Given this list of marker genes RIPK1, PTPN2, IL6, MIR99A, MIR26A1, IL6R, JAK2 (Janus kinase 2), CEBPA, GFI1, MIR98, YAP1, FER, MIRLET7C, C1QTNF4, SPI1, SRC, JAK1, MIR146A, STAT3, SMAD4, MIR125B1, MIRLET7A1, ST18, IL6ST, MIRLET7E, CTR9, MIR125A, here is a description of the gene set: Human Gene Set: GOBP_INTERLEUKIN_6_MEDIATED_SIGNALING_PATHWAY studied in species Homo sapiens The series of molecular signals initiated by interleukin-6 binding to a receptor on the surface of a target cell, and ending with the regulation of a downstream cellular process, e.g. transcription.